The following is a description of a gene set: Human Gene Set: MIR620 Genes predicted to be targets of miRBase v22 microRNA hsa-miR-620 in miRDB v6.0 with MirTarget v4 prediction scores > 80 (high confidence targets). species: Homo sapiens from publication Chen Y, Wang X (PMID 31504780), and this is the list of marker genes: EPPIN (epididymal peptidase inhibitor), UNC45B (NCBI Gene Id 191583), MKX, SLC24A2, IRF2BP2 (interferon regulatory factor 2 binding protein 2), HAS1, ANKRD44, EPB41L4B, HEXA, CD276, TXNRD2, GTDC1, C15orf40, CD209, RFC5, UBASH3B, ZCCHC14, POLI, TESC, ENTPD3, POLR3C, SGMS1, SDC4, SPTBN1, SENP5, CAMK4, SLC25A37, CIR1, SET, XKR9, CNTN3, LAMB4, ZDHHC15, MAN1A1, POLR1G, DCPS, EDIL3, CATSPERE, CCNT2, COPS4, N4BP2L1, STOML3, ATXN7L1, TMEM242, KLHDC3, HNRNPU, KRTAP4-11, PIK3CA, CBLIF, SH3BGRL2, PRR23C, CEP164, AFP (alpha fetoprotein), TCF20, ZIC5 (NCBI Gene Id 85416), ASPH, NDUFAF5, B9D1, GLI2, UNC5D, DGKE, GSPT1, HLA-DQA1, IQCJ, BACE1, PDE1C, CHSY1, C1orf174, WBP2NL, SLITRK2, OLA1, SMCO4, DNAAF3, BORCS7, POU2F3 (POU class 2 homeobox 3), PRSS37